The following is a description of a gene set: species: Homo sapiens Human Gene Set: HP_BAND_KERATOPATHY An abnormality of the cornea characterized by the deposition of calcium in a band across the central cornea, leading to decreased vision, foreign body sensation, and ocular irritation. Band keratopathy, and this is the list of marker genes: PTPN2, SLC4A4, COL18A1, IL2RB, CD247, GNAS, STAT4, VSX1, ANKRD55, OVOL2, PTPN22, IL2RA, JAG1, NOD2